The following is a description of a gene set: Abnormal fontanelle morphology studied in species Homo sapiens Human Gene Set: HP_ABNORMAL_FONTANELLE_MORPHOLOGY An abnormality of the fontanelle., and this is the list of marker genes: NCAPG2, HSD17B4, ETFDH, NEB (nebulin), AMER1, PEX2, B3GLCT, DUOX2, IYD, LMOD3, HRAS, RNU4ATAC (RNA, U4atac small nuclear), MID1, WT1, PEX26, H19, NSMCE3, KCNQ1, COL1A2, ACE, DEPDC5, SOX9, SLC34A3, GLI2, NDE1, KCNQ1OT1, COL1A1, GPX4, TWIST1, FOXE1, HOXD13, TSHR, DPYSL5, RPS6KA3, CAV1, LTBP4, ERCC1, COL11A1, WNT5A, FGFR2, SLC25A24, PAM16, ZSWIM6, PIGQ, ANTXR1 (NCBI Gene Id 84168), DICER1, PAX8, IFT140 (NCBI Gene Id 9742), GH1 (growth hormone 1), DDR2, REN, USP7, ALG9, SIX2, PEX3, MPDU1, ACTB, CYP2R1, FLNA, CRTAP, GNPTAB, ALPL, GLI3, CDKN1C, ASXL3, MEG3, POLR3A, DSE, FAM20C, EBP, GLIS3, POR (NCBI Gene Id 96440), ATR, HYMAI, FAM111A, TBCE, VDR, ALDH18A1, LRP2, INTU, TG, NAA10, MYCN, NSUN2, VARS1, ASPA, RTL1, DCHS1, ZMPSTE24, AGT, HESX1, HPGD, SH3PXD2B, HDAC4, ATP6V0A2, SMC3, LIG4, ADAMTS2, NFASC, PEX16, ORC1, CCDC22, ALG8, RUNX2, ALG1, DLK1, ATP6V1E1, PIEZO2, CDC45, ANKRD11, MAF, ATP7A, COG8, CHUK, ACTA1, TPO, PEX1, COX5A, P3H1, PLAGL1, MASP1, KLHL41, MTOR (mechanistic target of rapamycin kinase), GJA1, CTSK, ZIC1, BMPER, SHPK, KLHL40, LMNA, ZFX, GRB10, ETFA, CBFB, HNF1B, BANF1, PPIB, MMP2, NDUFAF3, PEX19, DVL1, RNU12 (NCBI Gene Id 574043), CHST14, ATP6V1A, SEC23A, CREBBP, AGTR1, PCGF2 (polycomb group ring finger 2), CTSD, NPHP3, ACTG1, NKX2-5, TALDO1, PEX10, CLCN3 (NCBI Gene Id 133073), CYP27B1, PYCR1, SPTBN1, ATRX, POU1F1, ETFB, FAT4, TOMM7 (NCBI Gene Id 54543), PROP1, SKI, COL11A2, PEX14, GNPAT, COG4, LHX1, DDX3X, MED12, KLF1, FIG4, VPS35L, LHX4, KIF7, INPPL1, PEX6, FGFR3, PPP2R5D, RBM10, CDH11, IGF2, PTDSS1, SETBP1, SLC25A19, SLC5A5, MVK, PEX13, NEPRO, RECQL4, NLRP3, UBR1, MSX2, SLC26A4, PIGA (NCBI Gene Id 5277), PEX12, DUOXA2, SMG9, ROR2, EP300, LHX3, ARX, PEX11B, PEX5, TSHB, NKX2-1